Given this list of marker genes Dnai1, Dync1li2, Lrrc61, Dync2i1, Dnal1, Dync2i2, Dnali1, Dnai4, Dync1i1, Dync1i2, Dync2li1, Trim58, Dnai3, Dnai2, Dync1li1 (dynein cytoplasmic 1 light intermediate chain 1), Clxn, here is a description of the gene set: species: Mus musculus Mouse Gene Set: GOMF_DYNEIN_HEAVY_CHAIN_BINDING Binding to a heavy chain of the dynein complex.